Given this list of marker genes ATP11B, ATP8B1, ATP8A2, ATP8A1, TMEM30B, TMEM30A, ATP11C, ATP11A, SCARB2 (NCBI Gene Id 950), here is a description of the gene set: The directed movement of aminophospholipids into, out of or within a cell, or between cells, by means of some agent such as a transporter or pore. Aminophospholipids contain phosphoric acid as a mono- or diester and an amino (NH2) group. Human Gene Set: GOBP_AMINOPHOSPHOLIPID_TRANSPORT species: Homo sapiens